Given this list of marker genes OAS3, DERL3, HAPLN3, IFIT3, PRPF31, IRF1, CCR3, CMPK2, IFI44L, MIR9-1HG, CETP, STAT1, EPSTI1, PARP9, CSF1, ETV7, GBP1, MTHFD1L, EPAS1, TYMP, CIMAP1B, here is a description of the gene set: studied in species Homo sapiens BACKGROUND: Vaccine development for influenza A/H5N1 is an important public health priority, but H5N1 vaccines are less immunogenic than seasonal influenza vaccines. Adjuvant System 03 (AS03) markedly enhances immune responses to H5N1 vaccine antigens, but the underlying molecular mechanisms are incompletely understood. OBJECTIVE: We compared the safety (primary endpoint), immunogenicity (secondary), gene expression (tertiary) and cytokine responses (exploratory) between AS03-adjuvanted and unadjuvanted inactivated split-virus H5N1 influenza vaccines. In a double-blinded clinical trial, we randomized twenty adults aged 18-49 to receive two doses of either AS03-adjuvanted (n = 10) or unadjuvanted (n = 10) H5N1 vaccine 28 days apart. We used a systems biology approach to characterize and correlate changes in serum cytokines, antibody titers, and gene expression levels in six immune cell types at 1, 3, 7, and 28 days after the first vaccination. RESULTS: Both vaccines were well-tolerated. Nine of 10 subjects in the adjuvanted group and 0/10 in the unadjuvanted group exhibited seroprotection (hemagglutination inhibition antibody titer > 1:40) at day 56. Within 24 hours of AS03-adjuvanted vaccination, increased serum levels of IL-6 and IP-10 were noted. Interferon signaling and antigen processing and presentation-related gene responses were induced in dendritic cells, monocytes, and neutrophils. Upregulation of MHC class II antigen presentation-related genes was seen in neutrophils. Three days after AS03-adjuvanted vaccine, upregulation of genes involved in cell cycle and division was detected in NK cells and correlated with serum levels of IP-10. Early upregulation of interferon signaling-related genes was also found to predict seroprotection 56 days after first vaccination. CONCLUSIONS: Using this cell-based systems approach, novel mechanisms of action for AS03-adjuvanted pandemic influenza vaccination were observed. TRIAL: ClinicalTrials.gov NCT01573312. Genes up-regulated in natural killer cell 1d vs 0d in adults (18-49) after exposure to inactivated monovalent influenza A/Indonesia/05/2005 H5N1 split-virus vaccine, time point 1D, administered i.m. Human Gene Set: HOWARD_NK_CELL_INACT_MONOV_INFLUENZA_A_INDONESIA_05_2005_H5N1_AGE_18_49YO_1DY_UP from publication Howard LM, Hoek KL, Goll JB, Samir P, Galassie A, Allos TM, Niu X, Gordy LE, Creech CB, Prasad N, Jensen TL, Hill H, Levy SE, Joyce S, Link AJ, Edwards KM (PMID 28099485)